Given this list of marker genes Ptpmt1, Pla2g6, Crls1, Slc27a1, Tafazzin, Plscr3, Tamm41, Gpam, Pgs1, here is a description of the gene set: Mouse Gene Set: GOBP_PHOSPHATIDYLGLYCEROL_BIOSYNTHETIC_PROCESS The chemical reactions and pathways resulting in the formation of phosphatidylglycerols, any of a class of phospholipids in which the phosphatidyl group is esterified to the hydroxyl group of glycerol. studied in species Mus musculus